The following is a description of a gene set: Genes down-regulated in macrophages with IL10 knockout in response to 30 min treatment by: LPS versus LPS and IL10. Human Gene Set: GSE9509_LPS_VS_LPS_AND_IL10_STIM_IL10_KO_MACROPHAGE_30MIN_DN species: Homo sapiens from publication El Kasmi KC, Smith AM, Williams L, Neale G, Panopoulos AD, Watowich SS, Häcker H, Foxwell BM, Murray PJ (PMID 18025162) IL-10 regulates anti-inflammatory signaling via the activation of STAT3, which in turn controls the induction of a gene expression program whose products execute inhibitory effects on pro-inflammatory mediator production. Here we show that IL-10 induces the expression of an ETS family transcriptional repressor, ETV3 and a helicase family co-repressor, SBNO2 (Strawberry notch homolog 2) in mouse and human macrophages. IL-10-mediated induction of ETV3 and SBNO2 expression was dependent upon both STAT3, and co-stimulus through the TLR pathway. We also observed that ETV3 expression was strongly induced by the STAT3 pathway induced by IL-10 but not STAT3 signaling activated by IL-6, which cannot activate the anti-inflammatory signaling pathway. ETV3 and SBNO2 specifically repressed NF-kB-mediated transcription and can physically interact. Collectively our data suggest that ETV3 and SBNO2 are components of the pathways that contribute to the downstream anti-inflammatory effects of IL-10. We compared expression profiles of macrophages isolated from IL-10 -/- mice. Macrophages were treated with either LPS or LPS plus IL-10. Treatment times were 10, 20 and 30 minutes., and this is the list of marker genes: CASP7, RIPOR1, DGKD, CAPN14, CYFIP2, TSPAN14, EPC2, MDM2, PPP3CC, SLC35D1, KDM6A, DCP2, ECT2, CKS1B, FCMR, CSGALNACT1, TROAP (trophinin associated protein), RAB15, CRNDE, EDEM1, FOXO1, CCNE2, DACT1, KDM4C (NCBI Gene Id 23081), FREY1, CYGB, CENPE, PDS5B, GINS4, CMTM7, PPP1R18, MYOM2, PXDN, HHIP, SLC7A3, KIAA1671, KIF23, STAG3, KHNYN, NPY, POU2AF1, ZNF492, DDR1, H1-5, MT1X, F2RL3, TLE1, HRK, MYBL2, KDM2B, CD72, DBN1, NUP50, CRIP1, FLT1, DGKA, GAB2, STAM, CKMT2, POLQ, PIK3CD, PLA2G15, CSH1, KANK2, CCNT2, CTNNAL1, LRIG1, CCDC81, TNFSF8, DTX1, CHST15, LEF1-AS1, ST6GALNAC4, CDK9, RAG1, TAGLN, TAC1, UBE2C, INTS15, E2F2, CD79B, NKX6-3, ATP1A3, BTG2, CENPU (centromere protein U), UBASH3B, SMC4, MYLIP, SESTD1, RUBCNL, SMIM3, CLSPN, CEP135, CREBBP, VPREB1, ZNF101, EIF2AK3, PAX5, ZNF681, PKD2, TUBA4A, NCLN, TADA2B, R3HCC1L, ENTPD4, CD22, NCAPH, SAP30, BTG1, GLRX, BAHCC1, RANBP9, RAG2, IL17RA, E2F7, PHF13, POLA2, CALM1, CENPS, LINC01013 (NCBI Gene Id 100507254), TAPT1, DEPP1, E2F8, MAP1LC3B, FHIT, ERO1B, CDC25B, CD24, STMN1, RASA2, TCP11L2, SHOC2, MTA3, LGR6, H4C8, NTAN1, LILRA2, EBF1, CFAP92, CD38, SYNE3, NIBAN3, FBXO5, ZHX2 (zinc fingers and homeoboxes 2), FANCB, SIAH2, NIPSNAP3B, ESPL1, HPS4, IGHV5-78, KCTD6, TCF4 (transcription factor 4), KATNAL1, ATOSA, WFS1, HASPIN, CCNB2, CD19, COL5A1, SNX30, FAM53B, NEIL1, INO80C, DOK3, PTPRE, LEF1, GAL3ST4, ARPP21, CD9, H3C3, FOXR1, VPREB3, RIMS3, MLXIP, CCNG2, GFI1, MICB, CKAP2L (NCBI Gene Id 150468), ARHGAP27 (Rho GTPase activating protein 27), ANLN, SSH2, ABCA1, PANX1, MICU2, GAB1, RNF152, PXK, CDCA8, MYLK, HMCES, MDFIC, HMHB1, GOLGA2P5